The following is a description of a gene set: Any process that activates or increases the frequency, rate or extent of neuron migration. Mouse Gene Set: GOBP_POSITIVE_REGULATION_OF_NEURON_MIGRATION studied in species Mus musculus, and this is the list of marker genes: Il1r1, Drd1, Pax6, Sema3a, Wdr62, Plaa, Ptprz1, Arhgef2, Mapk8, Mdk, Mapk8ip3, Arhgap32, Dab2ip, Shtn1, Fbxo31, Tbc1d24, Nsmf, Flna, Zfp609, Reln, Kif20b, Rapgef2, Sema6a, Nipbl